The following is a description of a gene set: from publication Mayburd AL, Martlínez A, Sackett D, Liu H, Shih J, Tauler J, Avis I, Mulshine JL (PMID 16551867) Genes up-regulated in H720 cells (lung cancer) after treatment with L663536 (MK886), an inhibitor of leukotriene biosynthesis. species: Homo sapiens Human Gene Set: MAYBURD_RESPONSE_TO_L663536_UP The small molecular inhibitor MK886 is known to block 5-lipoxygenase-activating protein ALOX5AP and shows antitumor activity in multiple human cell lines. The broad antitumor therapeutic window reported in vivo for MK886 in rodents supports further consideration of this structural class. Better understanding of the mode of action of the drug is important for application in humans to take place. Affymetrix microarray study was conducted to explore MK886 pharmacologic mechanism. Ingenuity Pathway Analysis software was applied to validate the results at the transcriptional level by putting them in the context of an experimental proteomic network. Genes most affected by MK886 included actin B and focal adhesion components. A subsequent National Cancer Institute-60 panel study, RT-PCR validation followed by confocal microscopy, and Western blotting also pointed to actin B down-regulation, filamentous actin loss, and disorganization of the transcription machinery. In agreement with these observations, MK886 was found to enhance the effect of UV radiation in H720 lung cancer cell line. In light of the modification of cytoskeleton and cell motility by lipid phosphoinositide 3-kinase products, MK886 interaction with actin B might be biologically important. The low toxicity of MK886 in vivo was modeled and explained by binding and transport by dietary lipids. The rate of lipid absorbance is generally higher for tumors, suggesting a promise of a targeted liposome-based delivery system for this drug. These results suggest a novel antitumor pharmacologic mechanism., and this is the list of marker genes: IKZF1, EIF2AK3, ASXL2, SLC7A11, PLEKHG5, SF3A2, LINC00471, LINC02861, USP11, SMARCA4, SLC1A4, BROX, GARS1, TRIM8, TAFA2, SNX6, WDR19, HNRNPUL1, RAB17-DT, MED12, SLC38A2, IL1RAP, RFNG, LINC00472, YARS1, SGCZ, ARHGAP26, HDLBP, SEMA6B, ZFP41, ZNF346